The following is a description of a gene set: Reactome Pathway: Iron assimilation using enterobactin part of: Metal ion assimilation from the host studied in species Homo sapiens Enterobactin is the siderophore with the highest affinity for iron. It is the main compound in enterobacteria used for iron assimilation, but also by some other organisms. During infection the host restricts free iron by using host siderophores, but enterobactin is able to steal iron from these complexes because of higher affinity (Miethke & Marahiel 2007, Barber & Elde 2015)., and this is the list of marker genes: exbD, exbB, tonB, acrA, fepC, mdtC, acrB, entS, fepA, tolC, yqjH, macB, fepD, fes, mdtB, macA, fepG, mdtA, yqjI, fepB, acrD